The following is a description of a gene set: Reactome Pathway: Mitotic Telophase/Cytokinesis This event has been computationally inferred from an event that has been demonstrated in another species.<p>The inference is based on the homology mapping from PANTHER. Briefly, reactions for which all involved PhysicalEntities (in input, output and catalyst) have a mapped orthologue/paralogue (for complexes at least 75% of components must have a mapping) are inferred to the other species. part of: M Phase electronically inferred by orthology from the curated human pathway species: Mus musculus, and this is the list of marker genes: Kif20a, Stag1, Rad21, Plk1, Smc3 (NCBI Gene Id 13006)